The following is a description of a gene set: from publication Baus-Loncar M, Schmid J, Lalani el-N, Rosewell I, Goodlad RA, Stamp GW, Blin N, Kayademir T (PMID 16121031) Human Gene Set: BAUS_TFF2_TARGETS_DN studied in species Mus musculus Genes down-regulated in pyloric atrium with knockout of TFF2. BACKGROUND AND AIMS: The gastrointestinal trefoil factor family (TFF1, TFF2, TFF3) peptides are considered to play an important role in maintaining the integrity of the mucosa. The physiological role of TFF2 in the protection of the GI tract was investigated in TFF2 deficiency. METHODS: TFF2-/- mice were generated and differential expression of various genes was assessed by using a mouse expression microarray, quantitative real time PCR, Northern blots or immunohistochemistry. RESULTS: On an mRNA level we found 128 differentially expressed genes. We observed modulation of a number of crucial genes involved in innate and adaptive immunity in the TFF2-/- mice. Expression of proteasomal subunits genes (LMP2, LMP7 and PSMB5) involved in the MHC class I presentation pathway were modulated indicating the formation of immunoproteasomes improving antigen presentation. Expression of one subunit of a transporter (TAP1) responsible for importing degraded antigens into ER was increased, similarly to the BAG2 gene that modulates chaperone activity in ER helping proper loading on MHC class I molecules. Several mouse defensin (cryptdin) genes coding important intestinal microbicidal proteins were up-regulated as a consequence of TFF2 deficiency. Normally moderate expression of TFF3 was highly increased in stomach., and this is the list of marker genes: ART3, BEX4, PCP4, THRSP, CTSC, NAT8, OR2H2, BAG2, PRDX2, RBP4, DDX6, HEBP1